Given this list of marker genes TERB2, MAJIN, LMNA, SPDYA, SUN1, IFFO1, TERB1, here is a description of the gene set: Human Gene Set: GOBP_CHROMOSOME_ATTACHMENT_TO_THE_NUCLEAR_ENVELOPE The process in which chromatin is anchored to the nuclear envelope. species: Homo sapiens